The following is a description of a gene set: Genes in the cancer module 432. Human Gene Set: MODULE_432 species: Homo sapiens, and this is the list of marker genes: HMGCR, PMVK, HMGCS2, FDFT1, CNBP, EBP, MVD, MVK, HMGCS1, NSDHL, FDPS, SQLE, LSS, DHCR7, IDI1